The following is a description of a gene set: Human Gene Set: GOCC_CELL_BODY_MEMBRANE studied in species Homo sapiens The plasma membrane of a cell that bears surface projections such as axons, dendrites, cilia, or flagella, excluding the plasma membrane on cell projections., and this is the list of marker genes: SLC6A2, KCNC4, KCND2, FLRT1 (NCBI Gene Id 23769), ATP1B2, KCNB2, TACR3, KCNC3, UNC5A, CADM2, P2RY12, SLC12A2, DAB2IP, ATP1A3, CX3CR1, INSR, KCNC1, HPCA, CD22, THY1, SLC4A8, KCNB1, ADCY8, KCNE3, GABRA5, KCNA2, AMIGO1, RGS8, PIEZO2, GRIA1, KCNC2